Given this list of marker genes Gps1, Rbmx, Stk38, Txnl1, Rock2, Hsp90aa1, Msi2, Cul3 (cullin 3), Actn1 (NCBI Gene Id 94278), Cct2, Cct7, Srrm1, Vim, Cpsf7, Tra2b, Ddx39b, Rhobtb2, Myo6, Rock1, Cdc37, Rbbp6, Spen, Pde5a, Cops2, Hnrnpc, Rnf20, Rhobtb1, Twf1, Cct6a, Tmod3, Phip, Actg1, Cops4, Hsp90ab1, here is a description of the gene set: species: Mus musculus Mouse Gene Set: REACTOME_RHOBTB_GTPASE_CYCLE RHOBTB GTPase Cycle